Given this list of marker genes EIF4G2, AVPR2 (NCBI Gene Id 554), EIF5A, RXYLT1, HCLS1, TMCO6, FKBP7, DNAJC18, POFUT2, ANTXR2, RPP14, DLD, GNG10, ZWINT, ARL16, WDR6 (WD repeat domain 6), PAFAH2, PGK1, LPCAT1, PPME1, ECD, ELK3, MOGS, CRP, MTA2, DRG1, NEUROG1, PPP2CA, NFAM1, LSM12, RND3, ATP6V0B, PRPS1, SSBP4, SEC61A1, PPP3CB, RMC1, SLC35A4 (solute carrier family 35 member A4), ACTR6, WAS, GNG2, C11orf24, BAG2, ARMC1, TAF9, TMEM185A, IPO9, MCM3, BHLHE40, BTF3L4, DAP, OPN3, AP2A2, MTFR1, NDUFC2, FTSJ3, UBE2D3, DEGS2, SETD6, NIF3L1, METTL6, RNF128, CCNA2, DNAJC2, PTPN14, PIGM, CHAC2, MYDGF, FAM98A, ADRA2A, IFT22, OTUD6B, C16orf87, ELOVL1, MCM2, INO80C, MORF4L2, SHC1, NAB1, TUFM, CSNK2A2, XRCC6, CLDN4, PUM3, MRPL11, SF3A1 (splicing factor 3a subunit 1), ZFYVE21, PTGER2, CYRIB, PANK3, SNX4, MET, SIRPA, RPF1, SLC7A7, PMPCA, ESR2, KCNA3, NSUN2, PRICKLE1, TIMM8A, CDC42SE2, EEFSEC, SYPL1, ALDH6A1, PCTP, MAGOH, FAM118A, CLRN3, ARHGEF12, CHID1, ME1, UQCRB, NUBP1, CA13, PABPC4, CIAO1, SMARCAD1, LIMD1, DERL2, CSDE1, RRP8 (ribosomal RNA processing 8), NCBP1, ETFDH, IMPDH2, ETFRF1, TMEM59, TMEM165, OAT, SCAF8, ENPP2, CXXC1, ATPAF2, ITSN1 (intersectin 1), TIMM17B, EEF1G, EIF5, THOC1, UTP18, DACH1, PLBD2, CD244, PDCL, PTCD3, CLMP, PRDX6, MEF2A, PRKCI, MCUB, ERO1A, MMP8, ACOT9, SLC35A1, SEMA5A, ABCG2, ADSS2, NOL11, APIP, MAP2K6, IGHM, NDUFB2, FAM174A, RAB14, CFP, YBX1, PTPMT1, ATP1A1, TMIGD1, MMACHC, SLC19A2, NUP153, SSR1, LIMK1, QNG1, IRS2, CHD1L, RIOK2, NAA30, DYNLT3, WDR75, DHCR7, E2F6, HELB, NAA10, GRHPR, LMAN1, PLD1, RBM19, HDLBP, DDT, MOB4, RAB32 (RAB32, member RAS oncogene family), SMPDL3B, C11orf58, IVNS1ABP, SLC22A4, ADAM9, MRPL45, RPA3, here is a description of the gene set: Genes down-regulated in comparison of dendritic cells (DC) stimulated with poly(I:C) (TLR3 agonist) at 24 h versus DC cells stimulated with Gardiquimod (TLR7 agonist) at 24 h. studied in species Homo sapiens Human Gene Set: GSE17721_POLYIC_VS_GARDIQUIMOD_24H_BMDC_DN mouse primary BMDCs were stimulated with tlr ligands and gene expression changes were profiled on Affymetrix arrays from publication Amit I, Garber M, Chevrier N, Leite AP, Donner Y, Eisenhaure T, Guttman M, Grenier JK, Li W, Zuk O, Schubert LA, Birditt B, Shay T, Goren A, Zhang X, Smith Z, Deering R, McDonald RC, Cabili M, Bernstein BE, Rinn JL, Meissner A, Root DE, Hacohen N, Regev A (PMID 19729616)